The following is a description of a gene set: part of: Signaling by FGFR2 studied in species Mus musculus Reactome Pathway: Downstream signaling of activated FGFR2 electronically inferred by orthology from the curated human pathway This event has been computationally inferred from an event that has been demonstrated in another species.<p>The inference is based on the homology mapping from PANTHER. Briefly, reactions for which all involved PhysicalEntities (in input, output and catalyst) have a mapped orthologue/paralogue (for complexes at least 75% of components must have a mapping) are inferred to the other species., and this is the list of marker genes: Fgf2, Fgf8, Grb2, Fgf7, Fgf23, Fgf6, Fgf20, Fgf5, Fgf17, Gab1, Fgf16, Frs2, Fgf22, Hras, Fgf1, Fgf10, Fgf4, Shc1